Given this list of marker genes Depdc5, Pip4k2c, Mapk15, Nlrp6, Tom1, Dcaf12, Zc3h12a, Gnai3, Pip4k2a, Atp5if1, Usp20, Ddit3, Gpr137 (NCBI Gene Id 225834), Optn, Ormdl3, Pafah1b2, Irgm1, Ube2a, Tpcn1, Fkbp8 (NCBI Gene Id 14232), Stk11 (NCBI Gene Id 97678), Fbxo7, Prkaa2, Usp36, Rnf31, Hmgb1, Smo, Larp1, Atg5, Herc1, Dap, Srebf1, Mtdh, Kat8, Kdr, Deptor, Lamp3, Foxk2, Pik3c2a, Stk38l, Npc1, Dnm1l, Adcy10 (adenylate cyclase 10), Hk2, Snx4, Mapk8, Trib3, Lmx1b, Tbc1d25, Dapl1, Plk3, Nprl3, Mapt, Iigp1, Mefv, Calcoco2, Atg12, Tsc2, Trim27, Tbc1d14, Sesn1, Ager, Eif2ak1, Ambra1, Trem2, Ubr4, Atg101, Ulk2, Ufl1, Pink1, Atm, Snca, Slc7a5, Wdr24, Igtp, Mtcl3, Rab39b, Lzts1, Flcn (folliculin), Smcr8, Atp6v0a1, Fbxl4, Hdac6, Slc35d3, Pik3r4, Tsc1, Endog, Kdm4a, Trp53, Mtcl1, Tnfaip3, Map2k1, Nupr1, Keap1, Golga2, Pycard, Atp13a2, Cptp, Rnf5, Xbp1, Sting1, Foxk1, Csnk2a1, Mlst8, Tpcn2, Hspb8, Atg2a, Foxo3, Plk2, Rubcn, Scoc, Itgb1, Klhl22, Fn1, Ehmt2, Sirt2, Nprl2, Ctsa, Sirt1, Ubqln2, Il10, Bcl2, Dcn, Cdk16, Pip4k2b (NCBI Gene Id 84507), Pik3r2, Nampt, Eif4g2, Ptpn22, Ripk2 (receptor (TNFRSF)-interacting serine-threonine kinase 2), Qsox1, Bok, Foxo1 (NCBI Gene Id 99758), Mtcl2, Phf23, Fez1, Cisd1, Nod2, Atg16l1, Eif4g1, Adrb2, Rmc1, Trim32, Mtmr9 (myotubularin related protein 9), Wdr45, Tbk1, Usp13, Rraga, Acer2, Ercc4, Trp53inp1, Prkn, Ulk1, Ulk3, Prkd1, Plekhf1, Usp30, Rab12, Tmem39a, Sptlc2, Depp1, Rragc, Bnip3, Casp1, Atg7 (autophagy related 7), Ifng, Cdk5rap3, Becn1, Ep300, Zdhhc19, Svip, Rragd, Vps13d, ENSMUSG00000144291, Rufy4, Tomm7, Mfsd8, Tlr9, Gfap, Irgq, Ddrgk1, Pim2, Trim13, Bag3, Irgm2, Supt5, Parl, Rnf41, Wdr41, Slc25a4, Elapor1 (endosome-lysosome associated apoptosis and autophagy regulator 1), Uvrag, Il10ra, Sesn3, Lepr, C9orf72, Atg13, Vps13c, Usp33, Wdr6, Rb1cc1, Atf6, Bid, Cln3, Gpsm1, Trim8 (NCBI Gene Id 93679), Ifnb1, Epm2a, Tigar, Rab3gap2, Snx7, Tspo, Lrrk2, Nrbp2, Sqstm1, Tlr2, Cers1, Atg14 (autophagy related 14), Usp10, Vdac1, Fbxw7, Lrsam1, Il3, Sh3glb1, Wac, Moap1, Rragb, Dapk1, Mid2, Wipi1, Mtor, Pptc7, Rptor, Hmox1, Bcl2l11 (NCBI Gene Id 76339), Zkscan3, Kat5, Htt, Rasip1, Lep, Mapk3, Clec16a, Sesn2, Dram2, Xpa, Ptk2, Snx30, Fyco1, Bmf, Tecpr1, Elavl1, Htra2, Cttn, Chuk, Fez2, Zmpste24, Ubqln4, Ikbkg, Cdc37 (NCBI Gene Id 12539), Slc25a5, Gba1, Huwe1, Lypla1, Sh3bp4, Dele1, Chmp4b, Snx18, Trim21, Rab8a, Il4, Scfd1, Sec22b, Ticam1, Washc1, Tfeb, Prkaa1, Cisd2, Cryba1, Poldip2, Gpr137b, Stat3, Wnk1, Ikbkb, Mul1, Fbxl2, Gsk3b, Rnf152, Trim23 (tripartite motif-containing 23), Ubqln1, Gsk3a, Mcl1, Bnip3l, Akt1, Erfe, Hif1a, Gata4, Setd2, Nod1, Adra1a, Tmem59, Rock1, Dram1, Sptlc1, Stub1, Itga5, Ralb, Trim65, Rab3gap1, Ccny, Mtm1, Map3k7, Pik3c3, here is a description of the gene set: Any process that modulates the frequency, rate or extent of autophagy. Autophagy is the process in which cells digest parts of their own cytoplasm. studied in species Mus musculus Mouse Gene Set: GOBP_REGULATION_OF_AUTOPHAGY